The following is a description of a gene set: Human Gene Set: GOMF_MITOGEN_ACTIVATED_PROTEIN_KINASE_P38_BINDING Binding to mitogen-activated protein kinase p38, an enzyme that catalyzes the transfer of phosphate from ATP to hydroxyl side chains on proteins in response to mitogen activation. studied in species Homo sapiens, and this is the list of marker genes: DUSP10, MAPK14 (NCBI Gene Id 1432), NFATC1, PRKG1, TAB1, DUSP16, PRMT1